Given this list of marker genes Bend3, Osbp, Fndc3a, Rbm27, Gstz1, Hapstr1 (HUWE1 associated protein modifying stress responses), Ssh2, Lrp8, Sap30bp, AI987944 (expressed sequence AI987944), Ano4, Adcy6, Slc25a44, Arrdc3, Mkrn2os, Zswim9, Sh3pxd2a, Dmbx1, Cyp2a4, Tspan33, Sh3rf3, Ctsc, Tfpi, Ring1, Myo6, Wsb1, Zmiz1 (NCBI Gene Id 328365), Pax9, Phldb2, Eif3d, Kdm5a, Fn3krp, Chmp3, Ppp4r4, Spon1, Cnnm4, Cntnap5b, Hars2, Cd2bp2, Kcna6, Rprd2, Zfp74, Srsf1 (serine and arginine-rich splicing factor 1), Stra6l, Ccdc121rt2, Vangl1, Igsf9b, Bcl2l11, Cluh, Tgif2, Zdhhc24, Rskr, Kdm4c, E030030I06Rik, Sorcs2, Nrf1, Nfix, Mocs1, Ina, Pkia, Ppp2r2a, Lce1c, Tmprss4 (transmembrane protease, serine 4), Adgrf1, Rasgrf2, Prdm16, Grik3, Ep300, Src, Mettl21e (NCBI Gene Id 403183), Ube2n (ubiquitin-conjugating enzyme E2N), Csgalnact1, Cbl, Fbxo41, Sar1a, Zik1, Vav3, Snx31, Zfp704, Orc3, Tshz3, Magi3, Mtmr4, Cnot4, Csnk2a1, Vps54, Npy1r (NCBI Gene Id 18166), Csnk1g1, Selenon, Megf11, Bri3, Mgll, Fmo5, Serpinb9b, Itgb3, Kirrel3, Sh2d2a, Tafa3, Eif4e (NCBI Gene Id 668879), Dgkg, Tle4, Slc18a2, Itgb1bp1, Jph4, Tsc1, Ccdc121rt3, here is a description of the gene set: from publication Chen Y, Wang X (PMID 31504780) studied in species Mus musculus Genes predicted to be targets of miRBase v22 microRNA mmu_miR_6934_3p in miRDB v6.0 with MirTarget v4 prediction scores > 80 (high confidence targets). Mouse Gene Set: MIR_6934_3P